The following is a description of a gene set: species: Homo sapiens Ion channels and ion homeostasis in relation to cardiac conduction is described in this section. Reactome Pathway: Ion homeostasis part of: Cardiac conduction, and this is the list of marker genes: ORAI1, FXYD7, ATP1B2, ATP1A2, ATP2A1, CASQ1, ASPH, FKBP1B, PRKACA, FXYD3 (FXYD domain containing ion transport regulator 3), RYR3, CAMK2G, ATP1B1, ITPR1, TRDN, ATP1A3, SLN, SLC8A3, ATP1B3, FXYD2, NOS1, SRI, CAMK2A, SLC8A1, ATP2B2, STIM1, ITPR2, FXYD4, ATP1A1, ITPR3, AHCYL1, ORAI2, FXYD6, ATP2A3, RYR1, ATP2B4, TRPC1, CAMK2D, FXYD1, DMPK, SLC8A2, CAMK2B, ATP2B3, ABCC9, TNNI3, KCNJ11, ATP1A4, CASQ2, CALM1, PLN, RYR2, CLIC2, ATP2A2, ATP2B1